The following is a description of a gene set: Human Gene Set: GOBP_REGULATION_OF_MEMBRANE_LIPID_METABOLIC_PROCESS species: Homo sapiens Any process that modulates the frequency, rate or extent of membrane lipid metabolic process., and this is the list of marker genes: ORMDL1, ABCA2, MIR127, PLA2G6, MIR195, PRKAA1, SIRT3, SCARB2, PAQR4, ORMDL3 (ORMDL sphingolipid biosynthesis regulator 3), SPHK2, TNF, MIR16-1, CCN1, SAMD8, TNFRSF1A, ENPP7, NSMAF, ORMDL2 (NCBI Gene Id 94102), ZNF750, SPHK1, PRKCD